Given this list of marker genes Gm29866, Xlr4a, Fshr, Nectin2, Zpbp2, Garin5b, Nup210l, Tmprss12, Iqcf1, Dpy19l2, Slc22a14, Gm20817, Slxl1, Gm29276, Adad1, Zfp42, Adgb, Cfap69, Zpbp, Prkaca, Ift56, Gm21627, Ttll1, Tdrd5, Tcp11x2, Catsper3, Cfap61, Xlr, Gm21996, Gm10488, Garin1b, Cib1, Cabyr, Drc1, Gm20843, Nme5, Catsperd, Gm5169, Spink2, Fscn3, Garin3, Kit, Tssk2, Sox30, Spag16, Armc12, Rsph6a, Abhd2, Sun5 (NCBI Gene Id 76407), Poc1b, Septin4, Efcab9, Pla2g3, Rab1a, Selenof, Cdyl, H3f3b, Slirp, Fancg, Pdilt (NCBI Gene Id 71830), Strbp, Garin4, Fndc3a, Sbf1, Gm21117, Catsperb, Psme4, Pygo1, Armc2 (armadillo repeat containing 2), Gm28102, Xlr3c, Taf7l, AU040320, Mei1, Spata16, Prm1, Xlr3a, Gm28919, Ropn1l (NCBI Gene Id 252967), Rnase9, Xlr5a, Drc7 (NCBI Gene Id 672231), Ttc12, Iqcg, Slx, Pdcl2 (phosducin-like 2), Ptch1, Cfap52, Cfap57, Gm5168, Cep57, Pld6, Osbp2, Pithd1, Sec23ip, H2al2a, Dld, Kat5, Pmfbp1 (NCBI Gene Id 67322), Dnhd1, Alms1 (NCBI Gene Id 381791), Iqcn, Spaca1, Prkg1, Adrm1, Sly, Ccdc38, Gm20870 (NCBI Gene Id 73329), Ift88, Gm5934, Cfap221, Hmgb2, Dmrtc2, Pfn4, Fsip2, Zmynd12, Gm1140, Ehmt2, Tssk1, Izumo3, Nphp1, Tmf1, Lrrc46, Qki, Slc26a3, Ythdc2, Gm773, Insl6, Rhbdd1, Xlr4c, Stk11, Ccdc159, Sycp1, Hspa2, Gm2012, Cfap65, Mamld1, Gm20824, Mfsd14a (NCBI Gene Id 15247), Zmynd15, Cep128, Kdm3a, Spag6, Defb37, Pebp1, Adad2, Ccdc62 (coiled-coil domain containing 62, NCBI Gene Id 639165), Gm6121, Spem1, Gm28870 (NCBI Gene Id 102639895), Tssk3, Jam3, Armc3, Rfx2, Tnp2, Agfg1, Ybx2, Gm20911, Cfap43 (cilia and flagella associated protein 43), Fsip1, H2bc1, Meig1, Actl7a, H1f7, Brip1, Pank2, Sufu, Pacrg, Spink1, Slc9a8 (NCBI Gene Id 98868), Gm21760, Gm7958 (predicted gene 7958), Slc26a6, Trip13, Eqtn, Defb1, Ddias, Catsperz, Gm20890, Ccdc63, Dcaf17, Pygo2, Spef2, Sppl2c, Gk2, Tcp11, Dnali1, Bbs2, Vps54, Ift81, Ing2, Gm29554, Dhh, Cfap206, Tnk2, Cylc2, Tbpl1 (TATA box binding protein-like 1), Dmc1, Epc1, Gm28576, Ddx25, Klc3, Tnp1, Mkks, Rnf8, Zfy2, Calca, Tmem119, Tuba8, Ropn1, Gm28510, Tssk4 (NCBI Gene Id 76401), Bsph2, Mns1 (NCBI Gene Id 17427), Septin14, Ica1l, C2cd6, Gm10230, Bax, Axdnd1, Garin2, Adam7, Gm20736, Dnah1, Tpgs1, Svs3b, Rnf17 (ring finger protein 17), Garin1a, Bbof1, Pafah1b1, Bbs4, Spag17, Xlr5b, Cfap47, 1700013H16Rik, Piwil1, Tssk6 (testis-specific serine kinase 6), Gm5935, Ttll5, Vps13b, Jam2, Gm21095, Agfg2, Cfap58, Misfa, Prm2, Gm2030, Nsun2, Gm14525, Rimbp3, Gm4297, Ccdc136, Cftr, Gm20820, Sox3, Sycp3, Ccdc42, Chd5, Yif1b, Gm21865, Tbc1d20, Cylc1, Actl9, Pcsk4, Svs3a, Ccdc146, Frey1, Meioc, Gm1993, Hook1, Catsper2, Mast2, Spag6l (NCBI Gene Id 50525), Rsph1, Eif4g3, Cfap119, Dzip1, Xlr5c, Catsper4, Fxr1, Cfap54, 3830403N18Rik, Tarbp2, Ttc21a, Tbc1d21, Cfap70, Xlr4b, Spo11 (NCBI Gene Id 98973), Ube2b, Bscl2, Garin5a, Galntl5, Aff4, Spinkl, Adcy10, Cep131, Gli1, Catspere1, Tbata, Semg1, Spem3 (SPEM family member 3), Ube2j1, Stk33, Klhl10, Oca2, Cfap44, Gm21294, Celf1, Akap4, Neurl1a, Pln, Cabcoco1, Gm21858, Ccr6, Gopc, Catspere2, Bsph1, Acrbp, Gm28961, Cfap97d1, Cfap53, Brdt, Vdac3, Tsga8, Cfap157, Six5, Ccnb1ip1, Fam209, Rec8, Xlr3b, Rbm46, Chn2, here is a description of the gene set: Mouse Gene Set: GOBP_SPERMATID_DIFFERENTIATION species: Mus musculus The process whose specific outcome is the progression of a spermatid over time, from initial commitment of the cell to a specific fate, to the fully functional differentiated cell.